Given this list of marker genes CDH23, CDH1, JUP, CDH9, CTNND1, CDH7, CDH5, CDH12, DCHS1, CDH15, CDH17, APC2 (APC regulator of WNT signaling pathway 2), CDH6, CDH11, CDH2, CDH24, CDH4, CTNNA1, CDH10, CDH22, CTNNA2, CDHR3, CDH3, CDH8 (cadherin 8), CTNNB1, CDH19, CDH13, CDH18, APC, CDH20, CDH26, here is a description of the gene set: species: Homo sapiens Complex of peripheral cytoplasmic proteins (alpha-, beta- and gamma-catenin) that interact with the cytoplasmic region of uvomorulin/E-cadherin to connect it to the actin cytoskeleton. Human Gene Set: GOCC_CATENIN_COMPLEX